The following is a description of a gene set: studied in species Mus musculus from publication Yevshin I, Sharipov R, Kolmykov S, Kondrakhin Y, Kolpakov F (PMID 30445619) Mouse Gene Set: NFATC2_TARGET_GENES Genes containing one or more binding sites for (Nfatc2) in their promoter regions (TSS -1000,+100 bp) as identified by GTRD version 20.06 ChIP-seq harmonization., and this is the list of marker genes: Gm19710, Zmat3, Eepd1, Ipcef1, Spag9, Elovl1, Necap1, Pdzd7, Nr4a2, Lrif1, 1110002J07Rik, Gm26358 (NCBI Gene Id 115486233), Gm28707, Adi1, Ciart, Grn, Shisal2b, Alg9, Zfp574, P2ry10b, Slc16a13, Cluap1, Gphn, Gne, A430027C01Rik, Gm25081, Atp8b4, Dctn6, Zc3h3, Eea1, Cdkl3, Tlr3, Tbc1d25, Rps29, Chit1, Sema4d, Or10g1b (NCBI Gene Id 258268), Plod3, Tmcc3, Eno4, Fcgr1, Sp1, Cmc2, Mplkip, Gstcd, Mir15b, Dnah1, 3300005D01Rik, Phf11b, Lrrc8c, Enkur, Ift22, 9530082P21Rik, Mras, 9930014A18Rik, E2f8, Gimap9, Nck1, Ltbp3, Gm11346, Parvb, Plekha4, Aim2, Chrnb1, Ush1c, Cox7a1, Dnah6, Il7r, Rab5c, Dedd, Vcan, Fchsd1, Gga1 (NCBI Gene Id 73931), Trp53cor1, Lratd2, Ypel3 (NCBI Gene Id 68930), Havcr2, Notch1, Gm6209, 1810030O07Rik, Gm12606, Sap30, Tmem167, Laptm5, Mif-ps9, Nr1h2, Rit1, Mir142, Gm15471, Inpp5a (NCBI Gene Id 212111), Snord14a, Hfe, Rnf123, Hk2 (NCBI Gene Id 15277), Fbxw8, A930018P22Rik, Akap13, Bcl10 (NCBI Gene Id 99555), Gigyf2, Zc3hav1, Gm13584 (predicted gene 13584), Camkmt, Clcn7, Pot1b, Batf2, H2-Eb1, Pilrb2, Traj46, Oard1 (NCBI Gene Id 224841), Niban2, Trim45 (tripartite motif-containing 45), Fnip1, Rcbtb2, Eogt, Ffar2, Ccl3, Dpep2, Lasp1, Rnf214, Xrcc4, Gm30948, Ehd4, Gm807, Cd200r1, 1700025M24Rik, Cdk5, 1110019D14Rik, Mfsd12, Scimp, Srebf2 (sterol regulatory element binding factor 2), Cryl1, Nhlrc1, Oas1a, Pdlim2, Tmem109, Socs5, Vav3, Fcrl1, Rilpl2, Prkcd, Gm8199, Cdc14a, Gm25008, Cep44, C5ar1, Pmaip1, 4930456G14Rik, Polr2m, Sbds, Ccl12, Senp1, Tm6sf1, Tspan8, Kbtbd7, Scrt2, Sucnr1, Zfp444, Cfap96, Rin3, Mtbp, Bach2it1, Dynlt3, Nsa2, Ndufs8, Mrtfb, Pwwp3a, Gm14221, Brat1, Gm7854, Pla1a, Sestd1, Susd1, Ptpn22, Ctdsp1, Gpr82, Eef1g, Ccr1, Mir449c, Lsr (NCBI Gene Id 54135), Hmmr, Capn5, Gfm2, 1700003D09Rik (RIKEN cDNA 1700003D09 gene), Hnrnpl, Furin, Ezh2, Gm24927, Cfap43, Lcp2, Txlnb, Atp6v1a, Trdmt1, Lrrc8d, Banp, Cep250, Bcl2a1d (NCBI Gene Id 12047), Atg7, Dusp16, Gm15320, Cln3, C3ar1, Gm12711, Ufsp2, Gm19557, Nlk, Spred2, Cystm1, Dph3, Asf1a, Pef1, Creg2, Agtpbp1, Ppp1r12b, Dhx34, Lrrc51, Phf8, Kif5c, Exoc5, Farsb, Llgl1, Myo9a, Sult2b1, Trim12a, 8430423G03Rik, Nsun6, Rhoh, Mir5124a, Usp39, Gm37548, Mta2, Trem1, Gm17138, 4931440P22Rik, Snora24, Gpr35, Snord17, Pgap6, 2310010J17Rik, Ccl2, Tbce, Aig1, Celf5, 3110009E18Rik, Prkag2, Gstt3, Rwdd2b, Gtf3c2, Synj1, 2410002F23Rik, Gm31831, Mrps12, Tns1, Gm29609, Gm18830, Rab2b, Ap4m1, Hmgxb4, Pgghg, Gm17102, C030005K06Rik, Ggt6, Fbxo48, H4c1, Zfhx2, Prss2, Gtpbp8 (NCBI Gene Id 66067), Ehd1, Gm16311, Tbc1d10b, Mir3109, Cdca2, Vps13b, Tvp23a, Rpl21-ps1, Ints14, Mrpl11, Tmem116, Ctsa, Snrnp35, Uhmk1, Aak1, Or4c15b, Sgk1, Gm23099, Slc1a5, Gm6586, Hyal3, Hcst, Slc9a8, Irf5, Vmn1r4, Nab2, Inpp5b, Myo18a, Rabgef1, Cpt1a, Mcat, Eif3d, Nudt13, AV099323, Brd7, Ctsz, D330023K18Rik, Smim7, Cxcl2, 2010110K18Rik, Mfsd14b, 9930022D16Rik (RIKEN cDNA 9930022D16 gene), Birc5, Lrch1, Mst1, Mir16-2, Zfp335os, Map3k8, Tax1bp1, Cox5a, Dnaaf8 (NCBI Gene Id 74684), Nsun4, P4hb, Cstf2t, Ttll11, Atg16l1, Tafa3, Tagap, Cnrip1, Orai3, Tmigd3, Lamr1-ps1, Gm16046, Zfp91, Cdk2ap1, Nek8, Nbas, Picalm, Zswim4, Gm20655, Tex30, Ppat, Rcc1l, Sh3bp5l, Cerk, Gm33370, Nkg7, AI480526, Grk3, Ddx49, Spef2, Engase, Setd1b, Styk1, Angptl2, Esyt3, Cope, Il17d, Mink1, Litaf, Cd74, Tlcd1, Nat8f4, Ccr3, Cyb561, Aste1, Rps17, Sh2b3, Selenot, Ctu1, Or10aa1, Il1b, Nfkbie, Jaml, Cdh23, Trim30b, Brip1 (NCBI Gene Id 73108), Slc22a21, Cstdc4, Ampd2, Xdh, Tapbp, Spz1, Serpinb12, Mob1a, Saysd1, Csgalnact2, Pzp, Socs3, Mid1, Dennd4a, Aff1, Shisa5, Rab11fip3, Rab40c, Slc4a1ap, Cnot11, Lrrc66, Eaf1, Sugp2, Wsb2, Mettl6, Ltc4s, Fbxo8, Pldi (NCBI Gene Id 73616), Cct5, Gm24788, Gm22279, Mir1901, Cisd3, Odad3, Bnip2, Pex2, Gapt, H2-Ab1, Dusp18, H2-M6-ps, Slc3a2, Brd2, Rfwd3, Nit1, Polg (NCBI Gene Id 208850), Zfp330 (NCBI Gene Id 30932), Trps1, Get3, Galm, Tnks1bp1, Marchf6 (NCBI Gene Id 223455), Il1r2, Nek11, Tmem128 (NCBI Gene Id 66309), Cd300ld, Rai14, Tnfaip3, Nfkbil1, Tmem229b (NCBI Gene Id 268567), Hsd17b11, Tm9sf4, Unc13d, Dusp14, Hcfc1, Alkbh4, Prrc2a, Mef2c, Nfkbid, Hk1os, Nol8, Sgsm3, 4930551O13Rik, Sumo3, Slc7a11, Hnrnpll, Oasl2, Rin2, Nf2, Evi2, Oplah, Rheb, Otos, Ilf2, Thap11, Gpr160, Gab3, Dnajb12, Chd2, Crem, Stard13 (NCBI Gene Id 243362), Scn1b, Cpeb4 (NCBI Gene Id 67579), Cst3, Gm25855, A530041M06Rik, Ccl7, Leprot, Pnpo, Napa, Ctsc, Tnfaip2, Rufy4, Fxyd5, Cyp4v3, Cenpn, Xpot, Pcna, Smdt1, Sugct, Zfp110, Ddx41, Klhl20, Naglu, Atf4, Gm15573, Snx33, Nfkb2, 1810012K16Rik, Got2, Hmgb1, Atp5pb, BC005537, Yif1b, Sypl1, Denr, Tnfsf14, Snhg8, Gm12301, Ube2b, Slc2a6, Cfap45, Fmnl1, Cdin1 (CDAN1 interacting nuclease 1), Ptk2, Hexim2, Gm20618, Hnrnpc, Adora3, Slco3a1, 2310001H17Rik, Oas1c, Nucb1, Aldh3b1, Gm9888, Ftl1-ps1, Fgr, Junos (NCBI Gene Id 230451), Cdkn2d, Fbxo24, Nelfa, Rtn4, Zeb2os, Tec, Copa, Gm12367, Rab43, 2810405F17Rik, Chp1, Anp32a, Cish, B3gntl1, Arl1, H2-D1, Tmem79, Abcc1, Depdc5, Eif4b, Slamf6, Gm12925, Dusp6, Tpm3, Pole3, Arrb1, Fbxo28, Uba3, Ccdc38 (coiled-coil domain containing 38), Rwdd2a, Gm25894, Gask1b, Gna13, Abi1, Ubash3b, Tia1, Fos, Mef2a, Rars1 (NCBI Gene Id 76827), Nnt, Tnfsf8, Dcstamp, 2310034G01Rik, Npepps, Nupr1, Polr1g, Gls, Gm9929, Cfap418, 6030443J06Rik, Ube2t, Vps4a, Fastkd5, Gm32051, Sla, Agpat4, Morc2a, Thnsl1, Ddx3x, Rbm5, Slc11a1, Mrps18a, Pttg1ip, Txnl1 (NCBI Gene Id 53382), Arhgap19, Wdr77, Sdf4, Atpsckmt, Chd6, Dock10, Dstn, Clk1, Fscn1, 4933430I17Rik, Jak3, Igsf9, Rpl29, Thoc1, Lncpint, Mtmr9, Gm24382 (predicted gene, 24382), Hint1, Rnd2, Sh3bp5, Zwint, Sirt2, Slc25a38, Actg2, Polr2a, Stfa3, Cideb, Ndufs4, Casc3, Polr3c, Parp8, Slamf7, Tnip3, Dglucy, Parp11 (NCBI Gene Id 101187), Mir671, Gm7260, Rab11b, P2ry14, Larp4, Fam3c, Ap3d1, Slc36a3os, Ly96, Isyna1, Mirt1, Gm11292, Mob3b, Gm12134, Gpr68, Ctsl, Nos2, Cmpk1, Amz2, Tspan18, Mtdh, Gripap1, Nol4l, Cass4, 1700067G17Rik, Lrch4, Pithd1 (NCBI Gene Id 99969), Dpf2, Dynlt4 (dynein light chain Tctex-type 4), Il23a, Tbxas1, Rab8b, 1700037C18Rik, Wdr36, Mir8112, Dusp13b, Ttll4, S100pbp, Nudt16, Odad4, Ppp1r37, Kdm3b, Nemp2, Clec4a1, Per1, Acvr1b, Gm17324, Ctns, Cast, Pomt1, Iqch, Ap5m1, H3c11, Gm29152, Dnai3, Dbi, Apobr, Cdc123, Hspa5, 5031425F14Rik, Chst11, Abr, Slc26a6, Zfp672, Cpeb2, A630072L19Rik, Arl5b, Ubl3, Ccl6, Srr, Hyls1, Rpl36a, Pheta2, Gm6410, Lrrc28, Yars1, Ppp3r1, Rnpep, Marveld1, Evi2a, Tubgcp4, Plscr1, Mtch1, 2900005J15Rik, Emc10, Tnrc18, Traj47, Selenok, Ubn2, Phospho2, Slc31a2, Rab29, Nme1, Lgi4, Pou2f2, Atp6v1g2, Ptx3, Mettl13, Heatr5a, Ankhd1, Rela, Lmna, Nutf2, Snw1, Dhx16, Myg1, Myo1c, Tox4, Pecam1, Pigo, Ccdc18, Mgat1, Zfp560, Skp1, Oas1b, Fam98a, Plek, Ripor1, Ppp1r15b, Cd33, Psmd11, Synpo, Hikeshi, Itpkb (inositol 1,4,5-trisphosphate 3-kinase B), Kdm2b, Prrg4, Bivm, Mrpl13, Acp5 (NCBI Gene Id 11433), Ppm1d, D930020B18Rik, S100a4, Clec4b1, Slc25a15, Tdrd5, Arhgap9, Vma21, Itga4, Col15a1, Ttc39b, Zmym1, Cstf3, Nudcd2, Mon1a, Gch1, Nlrp1b, Ptch1, A430093F15Rik, Slc4a2, Nr4a1, Gm14009, Arhgap1, Aip (aryl-hydrocarbon receptor-interacting protein), Cst7, Kctd12, Ppp1r13l, Slc17a5, 2610035D17Rik, Fbxw4, Mir7653, Fundc1, Zeb2, Nlrp3, Gm14040, Ube2v1, Mir122, Capg, Nfxl1, Reep3, Arih2, Znhit1, Gon4l, Vps29, Kat2b, Gm26510, Ubald2, Irag2, Gm1335, Gimap5, Wipf1, Hps6, Hk1, Optn, Zfp386 (NCBI Gene Id 56220), Otx1, Cdc20b, Tiam1, Nfya (NCBI Gene Id 18044), Nr6a1, Tcf12, Gm23598, Gm6377, Nfkbib, Spef1l, Nlrx1, Mst1r, Adipor2 (adiponectin receptor 2), Tgif1, Cxcl9, Dcaf11, Gm15407, Acod1, Myo1d (NCBI Gene Id 52096), Calhm2, Meaf6, Rcan1, Rpl11, Prkar1b, Csta3, Ttll1, Siglecf, Socs1, Slx4, Elmod2, Gm43351, Sec14l1, AI987944, Gm42141 (NCBI Gene Id 105246948), Nsmaf, Mmgt1, Kdm3a, Dapp1, Zmynd8, Rara, Lrp10, Tnf, Cdc25c, Zfp954, Dnttip2, Abcc2, Il18rap, Phb1, Ino80, 9430069I07Rik, Clec4e, Hcls1, Ssh2, Rps15a-ps5, Oxsm (NCBI Gene Id 97924), Ccl4, Hspa9, Lrrfip2, Psme3, Cltc, Gm20443, B230217C12Rik, Sorbs1, Mir5130, Cds1, Mfsd6, Gm4925, Ifnk, Ikzf2, Hacd4, Milr1, Mospd3, Pacsin3, Jpx, Cdc20, Mtpn, Neil1, Paics, Fbxl19, Rbks, Slc33a1, Pfkp, Zfp639, Ier3, Coro7 (NCBI Gene Id 78885), Gtf2e2, Ccdc51, Mphosph9, Ubox5, Crb3, D030028A08Rik, Tmem119 (NCBI Gene Id 231633), Arl8b, Gm15472, a, Cenpp, Shpk, Rny3, Pop4, Fbl, Traj33, Snrnp200, Glrx, Atf6, Ppih, Fblim1, Btbd6, Gfap, Ints4, Cybc1, 4833417C18Rik, Garin5a, Actr6, Tmem160, Nfkb1 (NCBI Gene Id 18033), Stfa2l1, Mdm4, Tcf3, Gm9920, S100a5, Polg2, Arhgap22, Mcm7, Egr2, Anxa11, Ptms, Fam171a2, Gm11592, 2500002B13Rik, Mypop, Slc41a1, Bcl7b, Dixdc1, Cdk5rap2, Slc66a3, Ppfia3, Zdhhc17, Frmd4b, Hace1, Mzt2, Bmf, Cops3, Ssc5d, Atp6v0b, Apoe, Supt7l, 1810024B03Rik, Trp53rkb, Isy1, Gpr171, 4930550C14Rik, Vps25, Srp68, Lyrm1, Pank2, Lmbrd1, Arhgap39 (NCBI Gene Id 28124), Cnih1, Ralgds, Gimap6, Gm13814, Csta2, Fhdc1, Ift57 (intraflagellar transport 57), Agbl3, Abl2, Gm25821, Emp1, Hdhd2, Plec, Stfa2, Bcl2a1c, Akr1b1, 1700017B05Rik, Glg1, Aldoa, Rps6kb1 (NCBI Gene Id 72508), Mlec, Scgb1a1, Slc25a39, Gosr2, Ppp1r11, Sars2, Orc5, Dock11, Pik3ca, Cfap126, Gm25323, 4930580E04Rik, Fam107b, Ripk2, Rad9b, Pde8a, Nepro, Pygb, Sesn2, Pes1, Arhgap4, Tug1, Mideas, Hat1, Zc3h7a, Tsga10, Zfp94, Ahcyl2, Slfn8, 1700066B17Rik, Pitpnm2, Gpr18, 8030453O22Rik, Nap1l2, Hsdl2, Iscu, Cox18, Ilf3, Gm26247, Nadk, Irak2, Uspl1, Or4c3 (olfactory receptor family 4 subfamily C member 3), Catip, Tonsl (NCBI Gene Id 72749), Gm16712, Ier3ip1, Slamf9, Ocm, Carmil1, Dok3, Pigv, Spcs3, Cd53, Itgb5, Zfp809, Cd82, Gm34780, Mgat4a, Fam53c, Tsbp1, Gm13781, Egr3, Gm11471, Atp6v0a2, Rbm39, Poglut2, Clcn4, Thrap3 (NCBI Gene Id 320018), Naa35, Dhrs9, Ccdc9, Isg20, Zkscan1, Cfap210, Pvr, A130010J15Rik, Arhgap18, Smim14, A530072M11Rik, Ermap, Anapc1, Inhba (inhibin beta-A), Poli, Spag1, Adamts6, Lbh, Rbm6, Fam110a, Pik3r6, Gm15587, Sec22b, Mir30c-1, H1f8, 6820431F20Rik, Adcy7, Ncapg, Rmnd5b, Ccdc50, U2af2, Pfdn2